The following is a description of a gene set: Human Gene Set: GOBP_NEGATIVE_REGULATION_OF_INFLAMMATORY_RESPONSE_TO_WOUNDING studied in species Homo sapiens Any process that stops, prevents, or reduces the frequency, rate or extent of the inflammatory response to wounding., and this is the list of marker genes: IL17A, DSG2, EXTL3, SIGLEC10, IL33, MDK, STAT3, REG3A, GIT1, PTPN6